Given this list of marker genes RAB3D, CHGA, ATG3 (NCBI Gene Id 64422), FMO2, SLC39A3, ZNF705EP, RBM17, TBC1D14, TP53INP2, SNX1, PIBF1, ILKAP, DMD, MLLT1, DPP8, TCERG1 (NCBI Gene Id 10915), FBXO33, CCL17, MGST3, FAM120A, PRM1, PDP2, ANKS4B (NCBI Gene Id 257629), CDC42BPB, STAT2, ARL1, CAMTA1, IFT140 (NCBI Gene Id 9742), EEF1A1, PLEKHA5, ANKFY1, DCX (doublecortin), APOBEC3F, ERI2, ZNF587, UBE2E3, STN1, PNPLA2, FANCD2OS, AMBP, SMUG1, AHCYL2, ZNF705D, SUMO1 (small ubiquitin like modifier 1), IRGQ, SLC25A5, TMC7 (transmembrane channel like 7), CEBPD, SEZ6L, PRRG4, CPNE4, EZH1, PRIMA1, USP4, SEL1L, C3orf70, ZNF329, TAT, RTKN2, ZNF80, here is a description of the gene set: Genes predicted to be targets of miRBase v22 microRNA hsa-miR-4433a-3p in miRDB v6.0 with MirTarget v4 prediction scores > 80 (high confidence targets). from publication Chen Y, Wang X (PMID 31504780) Human Gene Set: MIR4433A_3P studied in species Homo sapiens